Given this list of marker genes PKHD1 (NCBI Gene Id 5314), PSAP, SRSF2, LIPA, MED12, GBA1, DZIP1L, SMPD1, FASLG, ASXL1, RUNX1, SCARB2, HBB, TET2, CASP10, NOTCH1, FAS, CBL, ITCH, TULP3, here is a description of the gene set: species: Homo sapiens Hypersplenism A malfunctioning of the spleen in which it prematurely destroys red blood cells. Human Gene Set: HP_HYPERSPLENISM